The following is a description of a gene set: studied in species Homo sapiens Genes whose expression positively correlates with that of both ID1 and ID2 genes in a cohort of 285 patients with primaly AML (acule myelogenous leukemia). from publication Suh HC, Leeanansaksiri W, Ji M, Klarmann KD, Renn K, Gooya J, Smith D, McNiece I, Lugthart S, Valk PJ, Delwel R, Keller JR (PMID 18542061) Human Gene Set: SUH_COEXPRESSED_WITH_ID1_AND_ID2_UP Id1 is frequently overexpressed in many cancer cells, but the functional significance of these findings is not known. To determine if Id1 could contribute to the development of hematopoietic malignancy, we reconstituted mice with hematopoietic cells overexpressing Id1. We showed for the first time that deregulated expression of Id1 leads to a myeloproliferative disease in mice, and immortalizes myeloid progenitors in vitro. In human cells, we demonstrate that Id genes are expressed in human acute myelogenous leukemia cells, and that knock down of Id1 expression inhibits leukemic cell line growth, suggesting that Id1 is required for leukemic cell proliferation. These findings established a causal relationship between Id1 overexpression and hematologic malignancy. Thus, deregulated expression of Id1 may contribute to the initiation of myeloid malignancy, and Id1 may represent a potential therapeutic target for early stage intervention in the treatment of hematopoietic malignancy.Oncogene advance online publication, 9 June 2008; doi:10.1038/onc.2008.175., and this is the list of marker genes: UNC5A, RAB20, ID1, DDIT3 (NCBI Gene Id 92982), DNAJB1, NDRG1, SKIL, S100A6, GZF1, MYO1F, SQSTM1, ID2, ENSG00000301105 (novel transcript, antisense to GADD45B), GABARAPL1, BHLHE40, ATF5 (NCBI Gene Id 22809), MIDN, GADD45B, PLAU